Given this list of marker genes COL9A3, RSPRY1 (NCBI Gene Id 89970), HSPG2, PAM16, IFITM5, RPL13, ALPL, FN1, B3GALT6, COL11A1, GUSB, CREB3L1, TAPT1, AGA, LRP5, WNT1, GORAB, RINT1, RNU4ATAC, NANS, B3GAT3, TRPV4, PPIB, ARSK, LFNG, GNPNAT1, TRIP11, SPARC, FKBP10, PMM2, FUCA1, CSF1R, LBR, KIF22, INPPL1, FLNB, MRPS28, NEPRO, DDRGK1, GPX4 (glutathione peroxidase 4), MMP13, DHX37, COL10A1, DYM (dymeclin), XYLT1, IDH1, IFT43, TNFRSF11A (TNF receptor superfamily member 11a), CCN2, FGFR1 (NCBI Gene Id 84151), COL1A2 (NCBI Gene Id 1278), UFSP2, SMARCAL1, COL9A1, PLOD3, ADAMTSL2, KDELR2, SLC39A13, AIFM1, COL9A2, TOMM7, SERPINH1, PYCR1, MIA3, DDR2, COL2A1, COL1A1, SLC35D1, GLB1, ACP5, COG4, PLCB3, PCYT1A, MBTPS2, MAN2B1, HDAC6, EIF2AK3, PAPSS2, ZFX, ADA, FGFR3, CHST3, DNA2, RUNX2, EXOC6B, MAX, SLC25A24, TRAPPC2, SLC26A2, P3H1, TONSL, SMAD4, NEK1, CFAP410, LTBP3, CANT1, PHLDB1, BMP1, RAB33B, TMEM53, PTH1R, FLNA, RMRP, PLOD1 (NCBI Gene Id 5351), GALNS, ATP7A, ACAN, LAMA5, ABCC9, PLOD2, PRKG2, SGMS2, SEC24D, XYLT2, OCRL, COMP, TCIRG1, BMP4, ERI1, COL11A2, MATN3, BGN, SLC29A3, CCN6, EXTL3, KCNJ8, SFRP4 (NCBI Gene Id 6424), here is a description of the gene set: species: Homo sapiens Human Gene Set: HP_PLATYSPONDYLY Platyspondyly A flattened vertebral body shape with reduced distance between the vertebral endplates.